Given this list of marker genes USP12, BCS1L, DDX52, ARFIP2, EEF1D, ZNF500, SLC10A3, MCMBP, PDE6G, RCAN1, PSMA6, UBE2H, MREG, SNHG17, ELOB, BANK1, NVL, NOX3, PCDHA2, TCFL5, FGF4, TMED10, PTBP1, LNPEP, TAF4B, QSOX1 (quiescin sulfhydryl oxidase 1), ATF3, CTSH, TPD52L2 (NCBI Gene Id 7165), MAN2B1, UBL4A, RCE1, TBL1X, NFKBIE, ZFAND5, FAS, MCRS1, EPB41L3, DNASE1, PQBP1, SMURF2, ZC3H15, ODR4, KLHL18, NXF1, TP53BP1, GOT1, KRTAP2-4, OSGIN1, EPS8L3, GPATCH2L, KSR1, BLMH, ADAM15, GNL1, PGK1, MAP6D1, PMAIP1, GPX4, OFD1, DCUN1D4, RIOK3, AFF1, SIDT2, MRC2, IGKV1-5, NPFFR1, EMC3, KIF22, RPL39, TEX30, FBXO38, DDX5, SLC25A37, DAZAP1, CSRP1, RAPGEF2, ATP1A1, MTCH1, DND1, RPL7, PDZD8, CANT1, CRYBB2P1, PSTPIP2, PDCD11, SDC4, ZNF274, MTCL1, PPP1R11, TLE3, OSBPL2, MIF, SGTA, N4BP2L1, SLC4A2, DNPH1, GRB2, SLC7A7, GID8, ACTR5, PKNOX2, FLT3LG, RABGEF1, VCPKMT, GH1, HMCES, POGZ, ATN1 (atrophin 1), LPP, MINPP1, RUFY3, FCGR2C, IFRD2, MOCS3, DGKE (diacylglycerol kinase epsilon), KIF1B, SHB, HMG20B, ZCCHC14, GRK3, AP2S1, MOBP, PDE4B, RAP1B, CEMP1, PER2, UBL5, ADPGK, SCARF1, PELI1, MLYCD, MAPRE2, SMURF1, ZPR1 (NCBI Gene Id 95155), SLAMF1, TNIP2, MT1M, ZNF671 (zinc finger protein 671), PMM2, PDS5A, PDZD7, AP1S1, RRP12, FBXO21 (F-box protein 21), ISOC2, GGCT, ADAM20, BCL2L1, ERP44, AKAP13, GCM2, IL12B, DNAJC3, TPD52, MYH1 (myosin heavy chain 1), NEU1, DDX21, CTNNA1, MAT2A (methionine adenosyltransferase 2A), HCCS, SPATA2, ADGRE3, SOCS1, ARHGAP25, GPC5, RPL26L1, UQCRC1, SERF2, TAC1, EIF3J, SEC14L4, TUBB6, HNRNPA3P1, UBE2D1, TCERG1, ADGRL4, FAM163A, TRGV5, PGAP4, PPP1CB, DUSP2, DCTN5, MRPL24, ACAN, PALM, MKLN1, LTB4R2, KPNA1, GPI, TMEM208, C1orf216, RSL1D1, IFNA6, RHEB, RAB8B, FKBP5, ZNF34, CALM1, here is a description of the gene set: from publication Jeffrey KL, Brummer T, Rolph MS, Liu SM, Callejas NA, Grumont RJ, Gillieron C, Mackay F, Grey S, Camps M, Rommel C, Gerondakis SD, Mackay CR (PMID 16474395) studied in species Homo sapiens Genes down-regulated in comparison of untreated mast cells versus mast cells treated with IgE at 2 h. In the present study we used Affymetrix oligonucleotide microarrays to produce gene transcription profiles for the major leukocyte types in humans. This comprehensive dataset enabled us to not only establish which genes were expressed in each leukocyte type, but also which genes were expressed in each subset after activation. The used of a comprehensive dataset of gene profiles from all the major human leukocyte subsets enabled a novel and powerful means for identification of genes associated with single leukocyte subsets, or different immune paradigms. Human Gene Set: GSE3982_CTRL_VS_IGE_STIM_MAST_CELL_DN